Given this list of marker genes Lipa, Bap1, Brpf1, Flt3, Nr4a3, Fbxo4, Samd9l, Ceacam1, Itpkb, Mir125b-1, Mir125b-2, Gstp1, Uncx, here is a description of the gene set: The multiplication or reproduction of common myeloid progenitor cells, resulting in the expansion of a cell population. A common myeloid progenitor cell is a progenitor cell committed to the myeloid lineage. Mouse Gene Set: GOBP_COMMON_MYELOID_PROGENITOR_CELL_PROLIFERATION studied in species Mus musculus